The following is a description of a gene set: from publication Johnson EN, Appelbaum ER, Carpenter DC, Cox RF, Disa J, Foley JJ, Ghosh SK, Naselsky DP, Pullen MA, Sarau HM, Scheff SR, Steplewski KM, Zaks-Zilberman M, Aiyar N (PMID 15585845) Genes up-regulated in D10.G4.1 T cell line (0.8h): control versus treated with NMU. Human Gene Set: GSE1791_CTRL_VS_NEUROMEDINU_IN_T_CELL_LINE_0.8H_UP Effects of Neuromedin-U on gene expression in mouse D10.G4.1 T-cells natively expressing the GPCR Axor13 species: Homo sapiens, and this is the list of marker genes: MMAB, ENKUR, THAP11, IL10RB-DT, ITGB6, HNRNPA3P1, SURF2, TKT, NSUN4, ARL4C, PCYOX1L, MCRIP2, UQCC6, KDM4C, ZZEF1, NCAPH, IL18R1, TSSC4, SYT17, NISCH (nischarin), GSTP1, ANP32B, INTS9 (integrator complex subunit 9), ACVR2A, GSTM4, HTR3A, SPAM1, ORAI1, ALOX15B (NCBI Gene Id 247), S100P, CD24, MAF, JADE1, ECH1, POGLUT1, CCL22, DHX35, RNF181, COMMD1 (copper metabolism domain containing 1), FIG4, CPT1A, KCTD14, SYNGR2, ZBED1, NAPRT, TAPT1, ACACA, CCL17, SPINT2, ASB14, TRMT61B, PSME2, SNX1, MAPKAPK5, CLEC4G, ARHGAP25, TTC9C, PIEZO1, SRCAP, ETV6, KCNH2, TMT1A, BLTP2, APOO, POLRMT, NUP85, QSOX1, CHCHD1, PRPS1, CRYBG1, ZNF705G, OSBPL7, SNX17, CD209, APOL6, PTGER2, UBE2D4, INF2, EEF2K, ANKMY2, TBX19, GAS2L3, RAD51, MREG, SRI, CLTB, MRPL2, C1QB, DAG1, ARHGAP45, SNRNP200, FCER2, NOC4L, PHPT1, SLC4A7 (NCBI Gene Id 9497), EEPD1, APOL4, NUDT16L2P (NCBI Gene Id 152195), MAOA, MRPS33, TIMM23, MPHOSPH8, PDGFC, CHST7, TNFRSF4, ACAD9, B4GALNT1, HSD11B1, LEO1, APOL1, XPC, PYM1, AIFM1, NFXL1, ZBTB46, EPOP, CCDC137, TNFRSF11A, ALAS1, PPFIBP2, MALRD1, PLA1A, KDM2B, UBTF, CCL26, PLOD1, ZRSR2, RWDD2B, PSPH, PRADC1, INTS7 (integrator complex subunit 7), HDGF, BTBD18, SURF1, LHFPL6, PHYH, TRIB2 (NCBI Gene Id 28951, tribbles pseudokinase 2), CUTC, SFT2D2, COQ5, ZC3H3, C17orf58, DBI (NCBI Gene Id 1622), RFX5, ADI1, ALOX15, MGLL, NIT2, EMB, ASB13, STIM2, KRT2, ATRAID, CCL5 (C-C motif chemokine ligand 5), RAB42, GRK3, KCNE1, SH3GL3, SPHKAP, C1QC, ZFP36L1, SLC47A1, TENT5A, MFHAS1, GANC, TP53, MS4A4A, NDUFC2, PPP1R15B, RAB8A, ZNF543, DCXR, KISS1R, PCCB (propionyl-CoA carboxylase subunit beta), CEP164, SLCO3A1, ALDH2, PALLD, HHLA2, MBNL1-AS1, SCARB1, KCNK6, UMPS, RHOF, GSDMD, ZHX1, AKR1B1, PRPF31, PPP1R7, RBX1, GGTA1, DPYS, MOV10L1, COX8C, MGME1, SLC10A1, HSPB1